The following is a description of a gene set: species: Homo sapiens Human Gene Set: WP_ANGIOGENESIS Angiogenesis, and this is the list of marker genes: PLCG1, PTK2, ARNT, PDGFB, VEGFA, SRC, TEK, NOS3, MMP9, FLT1, MAPK14, AKT1, HIF1A, ANGPT1, KDR, PDGFRA, FGFR2, SMAD1, CREBBP, FGF2, PIK3CA, TIMP3, MAPK1, TIMP2